The following is a description of a gene set: Genes predicted to be targets of miRBase v22 microRNA mmu_miR_331_5p in miRDB v6.0 with MirTarget v4 prediction scores > 80 (high confidence targets). species: Mus musculus from publication Chen Y, Wang X (PMID 31504780) Mouse Gene Set: MIR_331_5P, and this is the list of marker genes: Atl3, Ccl21e, Fank1, Tnrc6c, Ccl21b, Sgcb, H2-Q4, Mcur1, Cdc73, Nat8f3, Asxl2, 5730480H06Rik, Fndc3b (fibronectin type III domain containing 3B, NCBI Gene Id 99920), Nr5a2, Phf14, Itga2b, Sec24d, Ifi203, Ssxb1, Ceacam12, Cdh9, Ccl21d, Ppfia1, Ssxb2, Treh, Ssxb9, Ccl21a, Pp2d1 (protein phosphatase 2C-like domain containing 1), Arhgap44, Hhex, Ranbp3l, Hebp2, Adgrf5, Rufy2, Zpbp, Ssxb10, Gins2, Ccng2, Trpc1, Rap2c, Kifbp, Rai2, Tigd4, Hnrnpr, Zfhx3, Ccl21f, Bbx (NCBI Gene Id 74503), Ifi207, Htr1f, Nat8f7, Zfp597, Nat8f6, Kpna3